The following is a description of a gene set: Catalysis of the hydrolysis of an acetyl group from a substrate molecule. studied in species Mus musculus Mouse Gene Set: GOMF_DEACETYLASE_ACTIVITY, and this is the list of marker genes: Ndst1, Macrod2, Hdac6, Ucn, Hopx, Hdac5, Ing2, Hdac9, Amdhd2, Mier2, Hdac4, Ndst4, Adprs, Aadac (arylacetamide deacetylase), Trp53, Sirt2, Ndst3, Hdac11, Sirt5, Pigl, Atxn3, Ncor1, Ydjc, Hdac2 (histone deacetylase 2), Sirt7, Hdac8, Sirt1, Oard1, Suds3, Sirt6, Macrod1, Hdac10, Ndst2, Sirt3, Hdac7, Sirt4, Mapk8, Mier1, Hdac3, Ski, Hdac1 (NCBI Gene Id 630524), Mta2